Given this list of marker genes Cd300a, Ptpn6, Cd300lf, Plscr2, Sphk2 (NCBI Gene Id 97350), Nr4a3, Cd300lb, Cd84, Havcr1, Timd5, Plscr1, Enpp3, Cftr, Lyn, Timd2, Rabgef1, Cnr1, Crlf2, Fer, Lilrb4a, Dppa1, Nectin2, Tslp, Cnr2, Cd226, Timd6, Milr1, Ptpre, here is a description of the gene set: species: Mus musculus Any process that modulates the frequency, rate, or extent of mast cell activation. Mouse Gene Set: GOBP_REGULATION_OF_MAST_CELL_ACTIVATION